Given this list of marker genes ITGB3, SCN11A, SCN2A, CHL1, SCN5A (sodium voltage-gated channel alpha subunit 5), ITGA9, DLG1 (discs large MAGUK scaffold protein 1), SPTB, MAP2K2, RPS6KA2, LAMC1, GAP43, DNM1, ITGA2B, NFASC, NRP1, NUMB, ITGB1, TUBB4A, SH3GL2, SCN3A, ITGA1, LAMB1, TUBB3, TUBB8B, SHTN1, SPTA1, SPTAN1, L1CAM, SCN1A, SPTBN1, CLTC, TUBA1B (tubulin alpha 1b), CNTN6, EPHB2, DLG3, AP2A2 (adaptor related protein complex 2 subunit alpha 2), RPS6KA1, TUBA4A, SCN8A, CNTN2, TUBA3E, DNM2, TUBA3C, AP2B1, RDX, SPTBN4, SCN10A, ANK1, CSNK2A2, ANK2, NRP2, KIF4B, ITGA5, KCNQ2, TUBA3D, RPS6KA5, CNTN1, SCN4B, DPYSL2, NCAN, NCAM1, DLG4, ACTB, MSN, AP2S1, TUBB8, LYPLA2, TUBB1, TUBA1A, SCN4A, LAMA1, SCN2B, ACTG1, ANK3, SPTBN5, VAV2, TUBB6, MAPK1, TUBB2A, KCNQ3, TUBA1C, SCN1B, RPS6KA6, CSNK2B, SDCBP, TUBA8, CLTA, EZR, RAC1, ITGA2, MAPK3, NRCAM, CSNK2A1, ITGAV, CD24 (CD24 molecule), SCN7A, FGFR1, EGFR, MAP2K1, TUBAL3, SPTBN2, DNM3, RPS6KA4, RPS6KA3, PAK1, AP2A1, TUBA4B, KIF4A, DCX, CNTNAP1, SCN3B, ITGA10, SRC, SCN9A, AP2M1, RANBP9, ALCAM, TUBB4B, TUBB2B, HSPA8, here is a description of the gene set: Human Gene Set: REACTOME_L1CAM_INTERACTIONS L1CAM interactions studied in species Homo sapiens